The following is a description of a gene set: Human Gene Set: MIR6134 from publication Chen Y, Wang X (PMID 31504780) studied in species Homo sapiens Genes predicted to be targets of miRBase v22 microRNA hsa-miR-6134 in miRDB v6.0 with MirTarget v4 prediction scores > 80 (high confidence targets)., and this is the list of marker genes: SLC8A3, ALDH7A1, POMC, RNF8, CCDC28B, HMOX2, SLC38A2, SNTB2, GARRE1, CCDC88A, ANKS1A, LRRC19, APBB2, KCTD1, UFL1 (NCBI Gene Id 23376), CFL2, AMPH, NECTIN1, MLEC, LSM12, SLC22A23, RIMS3, CCNE1, RHBDF1, B9D1, HIF1AN, TRIM39, ELOVL4, LY6G6C, HBEGF, ITPRIP, MTCL2, IL17RA (interleukin 17 receptor A), SEPSECS, PITPNM2, SLC45A2, ELFN2, REG3A, MARK1, NBR1, PARP1, ZSWIM5, RGS7BP, DPP9, SP3, PLXNA4, MBD2, CCNYL1, TAF4, ZNF618, C1orf21, CHP1, ZDHHC6, EVA1A, PCGF2, CLRN1, HSFY1, IL12RB1, BPNT2, HS3ST5, MLXIP, GLIS3, SMAD2, NALF2, PPP2R1A, HAX1, VPS13B, NSUN5, ANKRD50, ZZEF1, SLC2A3, LMLN, CCDC97, NUFIP2, STK4, FSD1 (fibronectin type III and SPRY domain containing 1), PNKD, NAMPT, CAPN12, XPO5, FIBCD1, SHOX, SLC5A6, RAD54B, MLLT6, HMGB3, AGFG1, LOXL3, USP49, PDS5B, CHKA, ALS2, H2BC21, COMMD10 (NCBI Gene Id 55955), ATF6, TMEM200B, HYDIN, NIPAL3, EPB41L1, TTC28, MORC2, RMND5A, ARID1A, SLC30A4, ARL4D, MEP1B, HSFY2, KRT80, NEURL4, TMEM198, HACE1, CA10, STMP1, C1QTNF1, NTRK3, OVOL1, S100A11, DGKA (NCBI Gene Id 1606), TNFSF12, FNDC9, NPAT, SQSTM1, EFNB3, TXNRD1, RNF150 (ring finger protein 150), FAM53B, AHNAK2, ERCC3, TIMP3, CHD5, PPM1M, OSBPL11, DUSP18, SLC41A1